The following is a description of a gene set: B cells from human tonsil and blood were sorted using flow cytometry. The human samples were processed immediately ex-vivo using markers for known B cell subsets. Genes up-regulated in comparison of pre-germinal center B cells versus dark zone germinal center B cells. Human Gene Set: GSE12845_PRE_GC_VS_DARKZONE_GC_TONSIL_BCELL_UP studied in species Homo sapiens from publication Longo NS, Lugar PL, Yavuz S, Zhang W, Krijger PH, Russ DE, Jima DD, Dave SS, Grammer AC, Lipsky PE (PMID 19023113), and this is the list of marker genes: IFI44, AHNAK, METTL8, IER3, IGHD, FCER1G, PHACTR1, TMEM176B, MAPK3, ARMCX1, KMT5B, IPP, APRT, CYP3A4, MED1, NPC2, GPR183, SPARC, PRKX, ZNF696, HCK, STAG3L1, APOBEC3C, RALGDS, PDGFC, CD200, TNFSF13, ZBP1, ZFP36, GPR153, CLEC2B, PTGDS, IGFBP2, HLA-A, IFITM2, PFDN5 (NCBI Gene Id 5204), IL6ST, SKIL, CXCL2, TNFRSF14, PLAC8, ICAM3, OPN3, IL6, APBA2, PSENEN, CD44, GTPBP6, SNX29P2, TLR7, TNPO1, EOLA1, LST1, EEF1AKMT2, LGALS9, SLC26A1, BANK1, GOLGA2, RNASET2, IFITM3, HES1, CXCL1, CCR7, MARK2, PLA2G7, UBN1, IQSEC3, KLF2, SP110, SLCO1B3, IL6R, ACP5, SFSWAP, DNASE2, NAB2, LTBP3, DGLUCY, SH3BP2, PPP1R16B, RCVRN, MTF1, IL17RA, SIDT1, REST, BCAP31, CD72, HLA-E, TUBB6, LARS1, PGAP3 (NCBI Gene Id 93210), LY9, MAFB, ENTPD1, GOSR1, POGLUT1, ADAMDEC1, CSF1R, KPNB1, FCMR, PDE8A, UGCG, MT2A, FOLR1, RBM47, ALDOC, KIF21B, HTR4, IGFLR1, XPNPEP3, GLG1, BTN3A3, PLXND1, CROT, RNASE6, OAS2, RPS6KA5, ENPP2, GPX1, ST3GAL5, TRHDE, TYROBP, FAM162A, MBP, GPNMB, NHP2, SCN7A, MACF1, FOXO3, ESF1, PCK2, HAO2, IMPDH2, LAMC1, TMSB10, EPHB6, CCR6, CASP1, FLT1, RARRES1, PEX16, PARP12, SAP30L-AS1, SDF2L1, SNORA21, CTSB, TBC1D9, FNBP4, CCND2, PLA2G2D, PHF1, BRD3, ARID5A, ADAM8, CRYBA1, TAP1, RAB29, CHI3L2, IGHM, UBE2L6, LIMS2, CXCL8, PSAP, SMAD3, FNDC3B, IGLJ3, NFKBIA, RHOC, GAK, RGS5, SLC16A7, APOC1, SCML1, RASGRP2, NCOA2, DCTD, STK10, CD14, CACNA2D2, CNKSR2, C1orf54, WDR55, FGD2, CHST12, MTCL2, QTRT1, HLA-C, DDIT4, BLK, IFI6, PTPRK, GUSBP3, GSAP, IER2, TGIF1, LYZ, PTPRO